Given this list of marker genes Pla2g6, Gde1, Gdpd3, Abhd4, Pla2g4c (NCBI Gene Id 52126), Plb1, Pnpla6, Pla2g4f, Lipc, Abhd12b, Gdpd1, Cel, Alkbh5, Enpp2, Aspg, Lypla2, Pla2g15, Pla2g4b, Lypla1, Pla2g4a, Pnpla8, Pnpla7, Abhd12, here is a description of the gene set: Catalysis of the reaction: a 1-acyl-sn-glycero-3-phosphocholine + H2O = a fatty acid + H+ + sn-glycerol 3-phosphocholine. studied in species Mus musculus Mouse Gene Set: GOMF_LYSOPHOSPHOLIPASE_ACTIVITY